The following is a description of a gene set: Human Gene Set: TAVAZOIE_METASTASIS Putative metastasis genes: up-regulated in metastatic cell lines LM2 (lung) and BoM2 (bone) relative to the parental MDA-MB-231 line (breast adenocarcinoma). studied in species Homo sapiens from publication Tavazoie SF, Alarcón C, Oskarsson T, Padua D, Wang Q, Bos PD, Gerald WL, Massagué J (PMID 18185580) A search for general regulators of cancer metastasis has yielded a set of microRNAs for which expression is specifically lost as human breast cancer cells develop metastatic potential. Here we show that restoring the expression of these microRNAs in malignant cells suppresses lung and bone metastasis by human cancer cells in vivo. Of these microRNAs, miR-126 restoration reduces overall tumour growth and proliferation, whereas miR-335 inhibits metastatic cell invasion. miR-335 regulates a set of genes whose collective expression in a large cohort of human tumours is associated with risk of distal metastasis. miR-335 suppresses metastasis and migration through targeting of the progenitor cell transcription factor SOX4 and extracellular matrix component tenascin C. Expression of miR-126 and miR-335 is lost in the majority of primary breast tumours from patients who relapse, and the loss of expression of either microRNA is associated with poor distal metastasis-free survival. miR-335 and miR-126 are thus identified as metastasis suppressor microRNAs in human breast cancer., and this is the list of marker genes: STX11, NIPAL3, CYP3A43, EREG, CHIA, CCDC81, TSPAN12, ROBO1, HOXA7, CXCL12, ZNF257, TNC, RADX, KLHL11, MMP1, ZNF682, PRKN, PTPRN2 (protein tyrosine phosphatase receptor type N2), KYNU, HAPLN1 (hyaluronan and proteoglycan link protein 1), ANO1, PLN, KLHL28, XYLB, RARA, HPGD, SIGLEC8, VCL, CA8, IL13RA2, MAGEA3, FOXA2, GATM, SOX4, ABCB9, KHDC1L, PLP1, DDR1-DT, SPANXA1, LAMA4, MYEF2, GNRH1, GDF11, ABCG5, FRS2, TP53TG1, DLG2, DPYSL4, NKAIN1, KLF9, KISS1, TTC9, ZBED4, MEOX2, CD24P4, MAGED4B, EAF2 (NCBI Gene Id 55840), NLGN4Y, SSX2, THAP9, IGFBP5, ASMT, FCN2, MARCHF1, MDM2, ZDHHC17, RAP1GAP2, IFNA8, RGS2, F9, KCNJ15, COL1A1, CNTNAP2, GPR17, KIAA0087, AKAP9, CD24, USP9Y, CRP, ZNF750, AMPH, P2RX2, PTGS2, TRIM23, KRT81, LRP2BP, DZIP1 (DAZ interacting zinc finger protein 1), UTY, ALK, SULT1C2, KIDINS220, PLEKHS1, MTAP, FAM135A, MYOM1 (NCBI Gene Id 8736), MTMR7, CDC14A, CSF3, SERPINB2, FCHO1, EFCAB11, SPANXB1, PLCB1, LRRC31, H2AC11, PDGFRA, KLRC1, SSX1 (NCBI Gene Id 6756), EIF3K (NCBI Gene Id 55373)